Given this list of marker genes Cdk6, Mdm2, Cdk4, Erf, Cdkn2b, Mapk3, Uba52, Ets2, Mapk1, Ubb, Ubc, Rps27a, Ets1, Trp53, Id1, Mdm4, Uba52rt, here is a description of the gene set: Oncogene Induced Senescence studied in species Mus musculus Mouse Gene Set: REACTOME_ONCOGENE_INDUCED_SENESCENCE